The following is a description of a gene set: species: Mus musculus Mouse Gene Set: GOBP_REGULATION_OF_NUCLEOTIDE_BINDING_OLIGOMERIZATION_DOMAIN_CONTAINING_2_SIGNALING_PATHWAY Any process that modulates the frequency, rate, or extent of the nucleotide-binding oligomerization domain containing 2 (NOD2) pathway., and this is the list of marker genes: Tlr4, Hspa1b, Ptpn22, Znrf4, Slc15a4, Nagk, Tnfaip3, Slc15a3, Erbin, Peli3